Given this list of marker genes PSMB1, SUMO2, H3-3A, RPS12, DRG1, ANP32B, BCL7B, PCBP2, ZC3H15, SUMO3, SLC25A3, MRPL23, FAU, NCL, GDI2, EEF1D, DDX39B, EEF2, EIF3M, RPLP2, HNRNPA1, STRAP, HNRNPK, NACA, IDH3B, FAM168B, RPL18, SRP14, RALY, UBE2L3, DHX38, EIF4A1, CLIC1, HNRNPUL1, PSMB3, EIF4G2, SLC25A6, RPL24, ACP1, SART1, UQCRFS1, PUF60, RPS6, RPL6, CCT7, COX4I1, HUWE1, RPL21, MRPL9, U2AF1, RPS27A, RPL10A, HSP90AA1, HNRNPC, LSM14A, DDX49, TIAL1, UBE2I, USP22, RPL30, HDGF, RNPS1, YWHAZ, here is a description of the gene set: Human Gene Set: MORF_SART1 Neighborhood of SART1 squamous cell carcinoma antigen recognised by T cells in the MORF expression compendium Neighborhood of SART1 species: Homo sapiens